Given this list of marker genes CPLX1, HNRNPK, DYNC2I1, THUMPD1, TCF12, KDM4B, DHX16, AP1G1, NARS2, GTF2E2, SALL1, HSPA9, SMARCC2, RXYLT1, RAD51, VAC14, SMARCB1, AARS1, CARS1, GDF1, NELFA, CDK13, PPIL1, HESX1, MID1, GPC3, DNM1, ASXL1, ZNF335, FKRP, SMC1A, CRIPTO, MT-CO3, GGT1, LRP2, ARID1A, PMS2, SLC12A2, STAG2, PRRX1, WARS1, VAX1, EMX2, PORCN, NSD1 (nuclear receptor binding SET domain protein 1), DCX, B3GLCT, ZBTB18, CNOT1, FRMD4A, KDM5B, MFSD2A, CDH2, NPHP1, GTF2H5 (NCBI Gene Id 404672), NTN1, ACTG1 (NCBI Gene Id 71), CDON (cell adhesion associated, oncogene regulated), MT-ND5, ERCC6, IFT80, LUZP1, STIL, CIT, SEC31A, NUP37, WDR62, MT-TL1, PHC1, CDK5, ALX1, CDC40, CEP63, MT-TS2 (mitochondrially encoded tRNA-Ser (AGU/C) 2), SMARCD1, SASS6, CDK5RAP2, DPYD, DCC, POMT1, SUPT16H, SMARCE1, FGF8, TMEM260, CTU2, NDE1, DPH1, WBP4, MLH1, NFIA, DDX3X, ASPM, CENPF, PIEZO2, ANKLE2, OTUD5, CPLANE1, HIBCH (3-hydroxyisobutyryl-CoA hydrolase), NFIX, SKI, COL4A1, MRPS16, ZNF699, KANSL1, CEP41, PLK4, MMP23B, MED12, EOMES, TARS1, POU1F1, ARID2 (AT-rich interaction domain 2), PPP1R12A, RNF113A, TUBA1A, PDHB, MT-CO2, HCCS, LHX4, PRDM16, PUF60, DLL1, LRPPRC, GET4, CDK6, POLR3A, OSTM1, KATNB1, MT-CYB, TUBB, GPC4, YARS1 (tyrosyl-tRNA synthetase 1), FIG4, ARNT2, TUBB3, PDHX, FGFR2, PDHA1, AHDC1, FLVCR2, DHCR7, CEP152, POLR2A, POMGNT1, KRAS, MT-TQ, FOXA2, FAT4, CRPPA, FOXH1, SNF8, TRAPPC14, GPSM2, POMT2, ALX4, ALX3, KAT5, ZNF462, MKS1, ATRX, CENPE, MT-ND6, UBE4B, PPP2R3C, MT-ND1, WNT3, PTDSS1, TBC1D23, PYCR2, HYLS1 (NCBI Gene Id 50957, HYLS1 centriolar and ciliogenesis associated), PDYN, IGBP1, ARMC9, AMER1 (NCBI Gene Id 160176), MDH1, FH, SOX3 (SRY-box transcription factor 3), KCNAB2, ACBD6, AHI1, COG8, KIF7, PIGN, NSD2, SLC30A9, C2CD3, DPF2, FOXG1, MPDZ, TMEM237, INPP5E, CAMSAP1, LETM1, SMO, DYNC2I2, BCL11B, DAG1, B3GALNT2, ZIC1, CDC42BPB, HECTD4, L1CAM, NDUFAF5, PLCH1, CSF1R, DYNC1I2, SUZ12, SMARCA4, RSPO2, HSPG2, HNRNPU, MT-ND4, NODAL, MT-TW, DACT1, FANCI, SOX4, SIX6, KNL1, ABAT, NKX2-1, PPP2R1A, RTTN, POMGNT2, PLXNA1, FGFR1, VANGL2, YY1, MT-TF, BMP4, ARX, EML1, PROKR2, INTS11, DPYSL5, OTX2, RERE, PGAP1, MBTPS2, FRA10AC1, MED12L, COPB2, CREBBP, SIX3, CPT2, SPEN, SCYL2, LHX3, CDK8, GLI3, GLDC, GMPPB, GLI2, TBX4, ACTB, PROP1, MED25, SF3B2, PRKCZ, CLCN3, CYP11A1 (NCBI Gene Id 1583), RPGRIP1L, SLC12A6, ERCC5, TUBA8, SRPK3, PDPN, DHCR24, WDR4, FCSK, PIGG, ZSWIM6, TP73, CASZ1, ZIC2, EP300, MTHFR, PHGDH, CILK1, EFNB1, DCHS1 (dachsous cadherin-related 1), SOX2, EPG5 (NCBI Gene Id 654033), DDX59, COX7B, TRAPPC12, TBCK, NFIB, ZEB2, EHMT1, KIF26A, MT-TH, GABRD, MPLKIP, SLC25A1, RELN, CWF19L1, LMNB2, CEP120, TNR, RECQL4, ZNF148, LRRC32, PYCR1, H3-3A, POMK, RAC3, PTCH1, C12orf57, LONP1, DPH2, OFD1, CEP135, TAF13, KIF14, EARS2, PEX2, TCTN3, DIS3L2, MCPH1, SPG11 (NCBI Gene Id 80208), MCM7, TRAPPC10, KAT6B, RAB3GAP2, DYNC2H1 (dynein cytoplasmic 2 heavy chain 1), NCAPD3, MAN2C1, KIDINS220, MRPS25, BUB1B, FLI1, TGIF1, ROBO1, RAB34, TUBB2B, CC2D2A, WDR35, ARID1B, ADAT3, METTL5, KIAA0753, KIF15, SLC25A19, ERCC3, HNRNPR, DNAL4, CTBP1, FGFRL1, SOX11, GAS1, LARGE1, RAB3GAP1 (NCBI Gene Id 338380), FKTN, MT-CO1, B4GAT1, SARS1, DISP1, HS2ST1, GPX4, TTC5, RNU4ATAC, SHH, FANCD2, ERCC2, CFC1, SUFU (SUFU negative regulator of hedgehog signaling), NDUFB11, here is a description of the gene set: Agenesis of corpus callosum species: Homo sapiens Human Gene Set: HP_AGENESIS_OF_CORPUS_CALLOSUM Absence of the corpus callosum as a result of the failure of the corpus callosum to develop, which can be the result of a failure in any one of the multiple steps of callosal development including cellular proliferation and migration, axonal growth or glial patterning at the midline.